The following is a description of a gene set: Any epithelial cell proliferation that is involved in renal tubule morphogenesis. species: Mus musculus Mouse Gene Set: GOBP_EPITHELIAL_CELL_PROLIFERATION_INVOLVED_IN_RENAL_TUBULE_MORPHOGENESIS, and this is the list of marker genes: BC028528, Mef2c, Lgr5, Mtss1, Lgr4